The following is a description of a gene set: Human Gene Set: GOBP_ALPHA_BETA_T_CELL_ACTIVATION The change in morphology and behavior of an alpha-beta T cell resulting from exposure to a mitogen, cytokine, chemokine, cellular ligand, or an antigen for which it is specific. species: Homo sapiens, and this is the list of marker genes: TCIRG1, SEMA4A, CD274, BAG6, EBI3, PIK3R1, RORA, NKG7, FUT7, JAK3, CLEC4G, RIPK2, IL6, ANXA1, RHOA, BRD2, PTCRA, ADORA2A, ZBTB7B, BRAF, MIR21, CEBPB, LOXL3, IL6R, TMEM98, PNP, IL18R1, ABL1, TBK1, XCL1, NCR3, CCR2, SMAD7, ADA, SOCS5, SPN, CARD11, TNFSF4, IRF4, NFKBIZ, NKAP, LGALS9, MYC, CTSL, TNFRSF14, ZNF683, IL12A, HLA-DRB1, TWSG1, HLA-A, IL15, BRD4, CD3D, FOSL2, LY9, SLC4A2, CLEC4A, RSAD2, CD69, BCL6, PTGER4, TOX, PRKCZ, ITCH, IL18, DOCK2, ICOSLG, CD55, MALT1, CD247, CRTAM, TNFSF8, KLRF1, WDFY4, KMT2A, RUNX1, CD160, CCL19, CLEC2B, PDP2, SH3RF1, STOML2, NLRP3, KLHL25, SHH, RORC, CD300A, IFNG, IHH, SLAMF6, IL12RB1, BCL2, ZFPM1, RASAL3, INS, MAPK8IP1, HLA-DRB3, CD3E, BCL11B, STAT4 (NCBI Gene Id 6775), NDFIP1, EP300, MEN1, IL2, ENTPD7, JAK2, NCR3LG1, SHB, STAT6, MTOR, BCL3, IRF1 (interferon regulatory factor 1), GLI3, EOMES, HSPH1, IL23R, IL21, SASH3, TARM1, STAT5A, RC3H2, JUNB, ICOS, HMGB1, AP3D1, PSMB11, IL12B, LGALS1, BATF, ITK, ZBTB16, SOCS1, IL23A, CD81, ZC3H12A, SOCS3, CDH26, JAK1, DAPL1, ZAP70, CD86, NCKAP1L, CD80, TBX21, IL4R, CD3G, VSIR, LEF1, ASCL2, PRR7, PRKCQ, LILRB4, RC3H1, RPL22, TRBC2, IL2RA, TNFSF18, ITPKB, AGER, LGALS9B, PRDM1, LGALS9C, FOXP1, IL6ST, HLA-DRA, TYK2, FOXP3, ATP7A, CBFB, OPA1, IL2RG, STAT3, RARA, ARG2, ATF2, HLX, AP3B1, LGALS3, MYB, GATA3, ARMC5, TRAC, CD83, RUNX3, NKX2-3, CBLB (Cbl proto-oncogene B), HLA-E, PLA2G2D, GPR65, HFE, CRACR2A, GPR18, TGFBR2, TRBC1, ELF4, CD28, GPR183, SYK, NFKBID, LILRB1, KCNK18, PTPRC, IL27, RELB